Given this list of marker genes ANXA5, ANTXR2, DHCR24, CLDN3, AHR, IDI1, CYP2C18, LGALS1, UGT2B4, HMGCS1, CYP26A1, GSTM5, SCD, CYB5B, FDPS, LGALSL, ASNS, ALDH1A1, CYP2A6, C11orf54, ENTPD5, GSTA2, CYP51A1, TMEM176A, CES2, CYP2B6, CD36, CSAD, AQP8, UGDH, GADD45B, MSMO1, SQLE, GSTM1, ACTG1, PRNP, HMOX1, TMEM97, GSTT3P, ETHE1, CYP7A1, PGD, LPL, SLCO1A2, here is a description of the gene set: NADPH-cytochrome P450 reductase (CPR) is an essential component for the function of many enzymes, including microsomal cytochrome P450 (P450) monooxygenases and heme oxygenases. In liver-Cpr-null (with liver-specific Cpr deletion) and Cpr-low (with reduced CPR expression in all organs examined) mouse models, a reduced serum cholesterol level and an induction of hepatic P450s were observed, whereas hepatomegaly and fatty liver were only observed in the liver-Cpr-null model. Our goal was to identify hepatic gene expression changes related to these phenotypes. Cpr-lox mice (with a floxed Cpr gene and normal CPR expression) were used as the control. Through microarray analysis, we identified many genes that were differentially expressed among the three groups of mice. We also recognized the 12 gene ontology terms that contained the most significantly changed gene expression in at least one of the two mouse models. We further uncovered potential mechanisms, such as an increased activation of constitutive androstane receptor and a decreased activation of peroxisomal proliferator-activated receptor-alpha by precursors of cholesterol biosynthesis, that underlie common changes (e.g. induction of multiple P450s and suppression of genes for fatty acid metabolism) in response to CPR loss in the two mouse models. Additionally, we observed model-specific gene expression changes, such as the induction of a fatty-acid translocase (Cd36 antigen) and the suppression of carnitine O-palmitoyltransferase 1 (Cpt1a) and acyl-CoA synthetase long chain family member 1 (Acsl1), that are potentially responsible for the severe hepatic lipidosis and an altered fatty acid profile observed in liver-Cpr-null mice. species: Mus musculus Genes up-regulated in liver from mice with liver specific knockout of POR. Human Gene Set: WENG_POR_TARGETS_LIVER_UP from publication Weng Y, DiRusso CC, Reilly AA, Black PN, Ding X (PMID 16006652)